Given this list of marker genes RN7SL720P, RAP1BP1, SAMM50P1, CER1, NFIB, RPL31P42, DENND4C, C11orf98P1, ZDHHC21, RRAGA, BNC2-AS1, MAP1LC3BP1, BNC2, RPS29P33, RN7SL98P, RPL7AP47, RPL7P33, RNU6-246P, NFIB-AS1, LINC03041, ADAMTSL1, LDHAP4, PSIP1P1, SNAPC3, NDUFA5P3, RPS6 (NCBI Gene Id 92956), CNTLN, MIR3152, FTH1P12, RNU6-14P, PSIP1, RNU6-1260P, RNU6-559P, TTC39B, PSMC3P1, CCDC171, RNU6-319P, HMGN2P16, ACER2, SAXO1, CDCA4P1, RNU6-264P, SLC24A2, RN7SKP258, PABPC1P11 (NCBI Gene Id 100421058), FREM1, SH3GL2, HAUS6, LSM1P1, ENSG00000309593, PLIN2, CLCN3P1 (NCBI Gene Id 100419056), SCARNA8, here is a description of the gene set: Human Gene Set: chr9p22 studied in species Homo sapiens